Given this list of marker genes Slc16a8, C1qb, Sgce, Sbpl, Grm3, Lipe, Slc31a1, Slc9a2, Hsp90ab1, Slc19a1, Jcad, Rasgrp2, Bbs7, Scimp, Neto2, Adam20, Scn1a, Hk1, Slc6a3, Lin7c, Pten, Snph, P2rx2, Slc6a20a, Grk2, Nsg1, Slc7a8, Dlg4, Trpm6, S100g, Msn, Plb1 (phospholipase B1), Plvap, Gpr37l1, Hspa1a, Atp6v0a4, Unc13a (NCBI Gene Id 73695), Zpld2, Thy1, Comt, Fgd2, Slc7a12, Slc6a8, Ptprt, Lrp6, Sorcs3, Prkcb, Drd3, Sema4f (NCBI Gene Id 20355), Clcn3, Kcnj8, Chrna2, Dpp4, Pkhd1l1, Gabrp, Hsp90aa1, Spry4, Sh3yl1, Slc23a2, Plpp2, Opn4, Slc36a1, Ap2s1, Lrrtm2, Fgr, Ush2a, Slc1a7, Glra1, Cavin3, Lrp4, Slc16a1, Osmr (NCBI Gene Id 18414), Numb, Atp6v1g1, P2ry12, Abcc3, Unc5a, Cdhr5, Gabrr1 (NCBI Gene Id 14408, gamma-aminobutyric acid type A receptor subunit rho 1), Vcam1, Mfsd10, Atp6v0d1, Ptgs2, Ceacam1, Cntn6, Fmr1, Adrb2, Mip, Iqgap1, Abcg5, Pde6g, Smo, Otof, Eps15 (NCBI Gene Id 73669), Src, Il18, Aqp4, Cldnd1, Slco1a1, Adam24, Akr1a1, BC034090, Stim1, Sbp, Slc38a4, Katnbl1, Nkd2, Hmcn1, Tshr, Slco1a4, Pkn2, Prkcg, Znrf2, Cacng5, Sipa1l3, Cldn6, Prkar1a, Cdh2, Magi2, Gabrd, Gpr151, Syap1, Tpm1, Adcy3, Kcnd1, Cldn7, Usp48, Utrn (NCBI Gene Id 22288), Slc26a9, Cask, Racgap1, Slco6d1, Naaladl1, Adam30, Vsig1, P2rx3, Il6ra, Slc8a1, Tamalin, Rapgef6, Ctsk, Adam17, Tacr1, Slc4a2, Abcc4, Kiss1, Gpr179 (G protein-coupled receptor 179), Phb1, Sigmar1, Zmynd10, Dsp, Shc4, Psg27, Bbs9, Cldn19, Tfpi, Dgkb, Nherf1, Slc1a6, Itpr3, Prom2, Oxtr, Krt19, Lcp1, Celsr3, Itga9, Abhd6, Bsn, Rab35, Adcyap1r1, Slco1b2, Itga5, Ms4a1, Htr5a, Slc22a6 (NCBI Gene Id 18399), Slc5a11, Stx3, Fas, Epb41, Gnaq, Pld1, Chrnb4, Vezt, Marcksl1, Slitrk3, Shisa9, Slc2a13, Napepld, Ddr2, Adcy8, Srpx2, Dsg1c, Ajap1, Fsd1 (fibronectin type 3 and SPRY domain-containing protein), Kcnq4, Cnga2, Rigi, Arrb2, Gucy2d, Myo1d, Cldn3, Tcirg1, Slc14a1, Abcb1b, Cripto, Kcnd3, Fermt1, Lrrtm3, Ager, Plppr4, P2ry2, Cav2, Dbn1, Snap29, Ttc8, Cnnm2, Slc20a2, Psg29, Nipsnap1, Kcnq5, Slc9b2, Pde6h, Lrp8, Anxa2 (NCBI Gene Id 12306), Lrfn5, Kcnd2, Neto1, Kctd12b, Rhcg, Cntn5, Gpr161, Mtmr2 (NCBI Gene Id 77116), Rgs9, Musk, Rasgrf1, Megf11, Pcdh8 (protocadherin 8), Eef1a1, Gucy2e, Best1, Dmtn, Slco1a7 (solute carrier organic anion transporter family, member 1a7), Slc12a3, Slc22a26, Slc22a22, Fat1, Slc27a4, Dnm3 (NCBI Gene Id 98663), Cnnm4, Flot2, Cd38, Trpv1, Prkar2a, Slc39a14, Stc1, Pdzd11, Psen2, Mlc1, Prkg2, Slc9a8, Mxra8, Hmcn2, Cdhr1, Drd4, Slc4a5, Rangrf, Abcc1, Slc1a5, Lzts1, Pcdh10, Htr3b, Lrfn4, Hmox1, Slc4a10, Pde4d, Smpd2, Scnn1b, Slc11a2, Adam6a, Trpa1, Cnih3, Pex19, Lhfpl4, Cd55b, Nod1, Cacna2d1, Trpm8, Dcc, Tek, Npy1r, Dram2, Pde6a, Syne1, Ank1, Cldn24 (NCBI Gene Id 434311), Adam21, Folr1, Ctsb, Akap9, Phlpp2, Snap91, Ehd2, Dmd, Kcnj9, Dnm2, Aif1l, Tspear, Plxnd1, Dlgap1, Adam34, Syt7, Chrnb2, Adam9, Gad2, Abcg8, Dcxr, Il1rapl1, Adam29, Septin2, Shisa7, Erc2, Nlgn2, Abca8a, Slc26a7, Cacna1a, Psg25, Olfm1 (NCBI Gene Id 99427), Stx19, Slc28a3, Sapcd2, Slc27a1, Oprl1, Atp1a1, Bmpr1a, Sema4d, Cd36, Myo7a, Glra3, Apc, Slc13a1 (NCBI Gene Id 55961), Rapgef4, Slc4a1, Cdh8, Ninj1, Slitrk5, Anxa13, Ptprh, Ppp1r9b, Tnik, Ptprs, Efna5, Pemt, Chrna5, Abca7, Atp2c2, Clstn2, Lmo7, Crkl (v-crk avian sarcoma virus CT10 oncogene homolog-like), Adam26b, Rala, Ect2, Rapgef3, Cd34, Spire2, Kcne4, Podxl, Rhbg (Rhesus blood group-associated B glycoprotein), Clcnka, Kif18a, Itgb5, Cbln1, Epb41l3, Dnaja3, Tpm3, Slc16a10, Abcb1a, Slc28a2b, Mal, Pth1r, Cavin4, Synj1, Ace (angiotensin I converting enzyme), Strn, Pard6g, Anxa1 (NCBI Gene Id 319730), Igf1r, Ripor2, Aif1 (allograft inflammatory factor 1), Grid2, Aph1a, Plek, Dsg1b, Efnb2, Fzd9, Slc4a4, Slc16a12, Ffar4, Vasp, Kcnj2, Grin1 (NCBI Gene Id 14810), Vdac1, Adam25, Kcne2, Wls, Plxnb1, Slc9a3, Adora3, Psg21, Htr1a, Gp2, Atp7a, Sema4c, Cacna1d, Pld2, Nlgn4l, Slc29a4, Wdr73, Vangl2 (NCBI Gene Id 93840), Pdzk1ip1, Slc7a7, Rab17, Kcnh1, Upk2, Cftr, Car12, Cadm3, Slc7a5, Slc16a6, Grik3, Gabrr2, Ppfia2, Pdxp, Wasf2, Pdgfrb, Fscn3, Inpp5k, Lcp2, Pdzk1, Tmem174, Slc34a3, Slc22a29, Arpc1a, Slc43a3, Pak1, Chrm2, Cit, Slc29a2, Gm4787, Gabra2, Atp4a, Tas2r108 (taste receptor, type 2, member 108), Lrrc4b, Drd2 (dopamine receptor D2), Ctnna2, Slitrk1 (SLIT and NTRK-like family, member 1), Ldlr, Met, Gna12, Anpep, Fosl1, Map4k2, Pick1, Kif20a, Car4, Nme1, Psg19, Ptpra, Kcnk1, Slitrk2, Slc1a2, Ndufs7, Grip2, Ghsr, Slc26a2, Chrna3, Hspb1, Emp2, Pakap, Fzd6, Slc5a2, Ntrk2, Lima1, Ntrk3, Adam1a, Fxyd1, Stxbp1, Prkaa1, Slc29a1 (solute carrier family 29 (nucleoside transporters), member 1), Nrcam, Dok7, Apc2, Slco1c1, Dnajc6, Sorbs2, Slc40a1, Slc16a2 (solute carrier family 16 (monocarboxylic acid transporters), member 2), Pkd1, Gabrq, Atp4b, Mpz, Aurka, Abcb5, Or2a7, Susd4, Nos1ap (nitric oxide synthase 1 (neuronal) adaptor protein), Efnb3, Nradd, Slc17a3, Mpp3, Elfn2 (leucine rich repeat and fibronectin type III, extracellular 2), Adora1, Gpc4, Slc6a9, Slc6a11 (solute carrier family 6 (neurotransmitter transporter, GABA), member 11), Sarm1, Car14, Flrt3, Adam34l, Adam23, Drd5, Naip1, Asic1, Bbip1, Mpdz, Slc16a5, Kctd12, Fxyd2, Iqce, Spef1, Vdr, Sptbn1, Bbs4 (NCBI Gene Id 52291), Eno1, Lrrtm1, Cxadr, Psg17, Pals1, Stxbp2, Grm1, Cys1, Atp2b3, Abcc5, Ndrg4, Gask1a, Cyp4a12b, Stxbp5, Mfsd4b1, Ift46 (intraflagellar transport 46), Pdlim4, Entpd2, Clcn2, Prom1, Cdkl5, Slc5a3, Arhgef2, Dnm1, Grin2b, Ngfr (NCBI Gene Id 18053), Atp6ap2, Lpar2, Gria2, Glra2, Slco1a6 (NCBI Gene Id 73773), Cdc42, Eno2, Kcnn2, Cltc, Cacna2d2, Ano1, Slc2a9, Oprd1, Trappc4, Amn (amnionless), Arrb1, Atp1b3, Atp6v1b2, Cnga1, B4galt1, Nrp2, Amn1, Rgs7bp, Tenm2, Shroom1, Sstr3, Slc5a8, Tirap, Gsg1l, Slc34a1, Alpk2, Cyp4a14, Rhoc, Atp6v0d2, Has2, Cbl, Rab5a, C1qa, Trpv5, Trpc1, Flot1, Stxbp3, Rab8a, Stx1a (NCBI Gene Id 20907), Adora2a, Adgrg2, Pdpn, Prkaca, Hspa8, Cdh9, Slc7a1, Eps8l3, Col13a1, Gabbr1, Dagla, Kcna4, Ncstn, Cyth2, Psd3, Entpd1, Slc30a5, Vamp3, Grin2d, Septin7, Cblif, Kcnc4, Vamp8, Spry2 (NCBI Gene Id 24064), Arhgap45, Map7, Nherf4, Rac1, Ncam1, Atp1b2, Klhdc8b, Htr1b, Atp6v1e1, Slc17a1, Ctbp1, Slc30a1, Slc39a5, Svil, Cd81, Cavin2, Sema4b, Zfyve19 (NCBI Gene Id 72008), Gnat3, Pdia3, Ceacam5, Muc20, P2ry1, Chrnb3, Ace2, Tgfa, Kcnk2 (NCBI Gene Id 98453), Evc2, Gabrg1, Cacng8, Adam26a, Adra2c, Ddr1, Abhd17b, Nod2, Magee1, Myo1c, Igsf11, Slc4a11, Rhoa, Enpp3, Ctsl (cathepsin L), Pard6a, Cav3, Epcam, Tmem114, Atp7b, Gpihbp1, Cdh17, Pllp, Sez6l, Ppp1cc, Slc5a10, Ptprd, Rab25 (NCBI Gene Id 99846), Nlgn1 (neuroligin 1), Pacsin2, Slc4a8, Spred1, Cldn8, Rab18, Sptbn2, Fgf22, Slco6c1, Patj, Slc2a7, Kcnab2, Slco2a1, Pkd1l1, Cyp4a31, Scn8a, Igsf9, Gabra3, Slc51b, Atp2b2, Crhr1, Akap1, Orai1, Thbd, Havcr1, Slc22a28 (solute carrier family 22, member 28), Nbea, Gap43, Gnat1, Ptger3, Slc6a18, Gnb1 (guanine nucleotide binding protein (G protein), beta 1), Kirrel1, Nos3 (NCBI Gene Id 71933), Krt8, Akap6, Slc17a2, Plcg2, Dpep1, Ceacam20, Slc22a5, Snap25, Abcc2, Slc24a4, Cyp4f14, Abcg2, Cd24a, Sytl4, Fscn1, Nrp1, Psd4, Htr3a, Cubn, Lin7b, Gabrb1, Akap7, Ceacam3, Slc7a11, Cdhr2 (NCBI Gene Id 639588), Mapk3, Tmem17, Ano6, Gabrb3, Slc8a3, Abcc10, Fxyd5, Slc13a3, Ryk, Cyp4a10, Slc23a1, Otoa (otoancorin), Slc5a7, Cyth1, Slc2a5, Asic5, Mgam, F2r, Prph, Ms4a4a, Epha7, Crb3, Slco3a1, Scn5a, Ceacam13 (NCBI Gene Id 72256), Cln3, Rab3gap2, Appl2, Mpp4, Epn1, Fxyd4, Chrm4, Shroom2, Abca1, Stx4a, Aqp3, Scarb1, Tmem231, Hax1, Ank3, Cacnb3, Robo2, Tsc2, Napb, Cdh16, Gpr157, Htt, Rims1, Epha2, Ntng1, Heph, Slc22a18, Adam22, Sntg1, Slc5a1, Pcmt1, Dnm1l (dynamin 1-like), Atp2b4, Plcg1, Cav1, Grik2, Septin6, Trpc4, Cnr1, Arf6, Rps3, Chrnd, Pianp, Mttp, Mtss2 (MTSS I-BAR domain containing 2), Adgrl1, Gabre, Scnn1a, Cr1l, Tmem67, Dtnb, Cnga4, Slc12a5, Slc6a5, Cyp4a32, Htr2a, Ncam2, Prrt1, Nherf2, Inppl1, Asic2, Cacng7, Chrna9, Upk1a, Fap, Pde2a, Marveld2, Adam10, Car2, Psen1, Grm7, Slc22a12, Slc34a2, Slc4a9, Kcnc1, Slc22a8, Erbb4, Glrb, Plec, Slc22a21, Neo1, Anxa4, Ctnna1, Nedd9, Aqp5, Farp1, Slc22a30, Gabrg3, Hpca, Cacna1c, Adgrl2, Pkhd1, Diaph1, Arl13b, Mosmo, Adgrl3, Scn11a, Gria1, Jag1, Dsg2, Adam1b, Kcna5, Nptx2, Pip5k1a, Adam4, Grin2c, Myh9, Itsn2, Dab2, Myof, Gnas, Pacsin1 (protein kinase C and casein kinase substrate in neurons 1), Vwc2, Kcnc2 (NCBI Gene Id 544750), Llgl1, Atp1a3, Cfap126, Anp32e, Cyba, Prr7, Wwc1, Calhm1, Prcd, Fzd3, Slc26a11, Slc22a3, Ap2a1, Sorbs1, Eps8l2, Chrna7, Adtrp, Tgfbr1, Slc6a6, Slc6a13, Adam39, Gnb5, Rab11a, Ptpn5, Atg9a, Cspg4, Best2, Prrt2, Prkab2, Cib1, Mtcl1, Shisa6, Cnih2, Slc38a3, Shroom4, Ache, Ezr, Shank3, Clic5, Adcy10, Ptprz1, Tacr3, Tjp1, Fcho2, Pfkm, Myrip, Tfrc, Fbxo2, Ctnnb1 (NCBI Gene Id 12387), Whrn, Kcnj4, Lrp2, Arl13a, Itga6, Shisa8, Scn2a, Micall1, Slc22a13, Fam107a, Cavin1, Pcdh17, Lrfn2, Mapre1, Slc22a19, Cadm4, Aspm, Clstn3, Psd2, Psg26, Kctd8, Nptn, Ptprj, Shank2, Ecrg4, Rtn4, Scrib, Arhgef18, Bcan, Acy3, Lin7a, Prkcz, Grm8 (glutamate receptor, metabotropic 8), Slc6a12, Slc46a1, Chrne, Drd1, Lrrc15, Stk39, Gabrg2, Lrrc4c, Mkln1, Elfn1, Kifap3, Mtdh, Nrg1, Srgap2, Ocel1, Pard3b, Rph3a, Syt11, Slc9a1, C5ar2, Slc28a2, Marcks, Rims2, Igsf9b, Ano2, Nlgn3, Pkd2, Akt2, Tiam1, Bbs1, Picalm, Grin2a, Plcd3 (NCBI Gene Id 72469), Pcdhb16, Tmub1, Kcnj16, Slc26a6, Slc39a3, Atp1b1, Gripap1, Slco4c1, Tbc1d10c, Crb1, Abcg3, Apba1, Slc47a2, Hspa1b, Slc16a3, Pip5k1c, Grin3b, C1qtnf5, Jak2, Chrm3, Rab11fip4, Cacng3, Hvcn1 (NCBI Gene Id 74096), Mylk, Stx1b (syntaxin 1B), Slc22a1, Cd177, Slc10a2, Kcnn4, Ntng2, Psenen, Zdhhc17, Syde2, Grm2, Pik3cb, Rapgef2, Canx, Slc6a20b, Kcnt1, Faim2, Hip1, Kif1b, Itgb1 (NCBI Gene Id 70812), Pde9a, Arc, Arpc2, Ptpro, Gphn, Cacna1h, Antxr1, Car9, Cldn25, Abhd17a, Afdn (NCBI Gene Id 240024), Slc17a4, Plpp1, Enpep, Men1, Grm4, Eppk1, Slc43a1, Slc6a4, Itpr1, Glra4, Ap2m1, Lingo2, Psg20, Npc1l1, Adam11, Chrna10 (cholinergic receptor, nicotinic, alpha polypeptide 10), Ptch1, Gjb6, Slc39a8, Scn10a, Plekha1 (NCBI Gene Id 338490), Lrrtm4, Akap5, Birc5, Psd, Adcy6, Mtmr9, P2rx6 (purinergic receptor P2X, ligand-gated ion channel, 6), Dock8, Oscp1, Slc51a, Ide, Slc47a1, Rims3, Plek2, Clca4a, Psg23, Slc6a19, Stx11, Rnf10, Adgrv1, Eps8, Fasl, Pdgfb, Slc43a2, Chrm5, Slc26a3, Eno1b, Cyp4a30b, Nt5e, Lpo, Nectin3, Slc22a27, Grm5, Chrna4, Ankrd45, Syt6, Epb41l1, 4930544G11Rik, Prickle2, Fxyd6, Ptgis, Iqsec2, Grin3a, Cldn5, Lhfpl5, Lypd11, Slc22a7, Slc12a6, Cacng2, Pard6b (par-6 family cell polarity regulator beta), Slc27a5, Fbxo45, Clstn1, Cdh10, Dtnbp1 (NCBI Gene Id 94245), Slc2a3, Cyp4a12a, Agtr1a, Lrfn1, Spn, Epb41l5, Lrp1, Flrt2, Dstyk, Cntnap2, Bmx, Nde1, Myo6, Cd44, Rhob, Tlr9 (NCBI Gene Id 81897), Itln1, Arf4, Cplx3, Kcnj6, C1qc (complement component 1, q subcomponent, C chain), Gabrr3, Slc15a1, Itga3, Slc14a2, Enpp1, Kctd16, Pappa2, Adgrb3, Slco4a1, Cd9, Abca8b, Rom1, Dll1, Erbb2 (NCBI Gene Id 13866), Gm2a, Bves, Slc2a2, Gpr158, Aqp7, Pitpnm1, Icam2, Ceacam11, Cyp4f18, Atp6v1a, Tmem30a, Twf1, Zc4h2, Syt1, Kcnj3, P2rx1, Scnn1g, Palm, Slc1a1, Sctr, Hcn4, Adgrb1, Crb2, Gabrb2, Napa, Hck, Grik4, Cryab, Itgb4, Kank1, Gpi1, Hpn, Slc7a13, Pard3, Calhm3, Igsf21, Rgs7, Mtmr6, Prkaa2, Syp, Tln1, Slc39a10, Dlg1, Mal2, Casr, Slc3a1, Ddn, Grm6, Nox4, Trpv4, Syne2, Cd300lg, Jup, Adam6b, Ptprq, Gabbr2, Arl6, Aqp1, Ank2, Atp1a2 (NCBI Gene Id 98660), Mchr1, Pde6b, Frmd6, Atf4, Rab11fip3, Ehd3, Gna13 (NCBI Gene Id 14674), Trpc2, Unc13c, Tmem108, Ceacam23, Chrng, Adra2a (adrenergic receptor, alpha 2a), Muc13, St14, Gja1, Kcnma1, Igsf5, Gpr88, Sspn, Frmpd2, Gnao1, Muc17, Dennd1a, Itsn1, Spire1, Lypd4, Clta, Rab21, Syde1, Cyp4a29, Gabra4, Slc26a4, Slc5a12, Chrna1, Cldn4, Ap2b1, Clrn2, Trem2, Bsnd, Nsg2, Pi4k2a, Shank1 (NCBI Gene Id 545962), Atp2b1, Kcna3, Itgb2l, Exoc3, Irs1, Upk1b, Kcnc3, Dlg3, Add2, Sh3bgrl3, Itpk1, Slc7a9, Baiap2, Notch1, Kcnj11, Amotl1, Txndc15, Slc9a4 (NCBI Gene Id 98735), Slc26a1, Syt3, Atp8b1, Ssh1, Nectin1, Cdh15, Kcnq1, Ptk2, Ttyh1, Clca2, Rp2, Lamp5, Bmpr2, Slco1a8, Lct, Gria3, Nrxn3, Plk4, Abcb4, Apbb1, Efcab7 (NCBI Gene Id 381610), Pkn1, Insr, Inpp5j, Hcn2, Aqp8, Upk3a, Bsg, Clmp, Gabra1, Cnksr2, Myo1a, Trf, Htr7, Rab14, Syndig1, Stk26, Cd46, Map2, Evc, Gria4 (glutamate receptor, ionotropic, AMPA4 (alpha 4)), Kl, Slc12a1, Kncn, Il10ra, Cpe, Hdac6, Slc13a5, Slc6a14, Csmd2, Clasp2, Cldn1, Septin3, Myh10, Ptprf, Slc28a1, Dlc1, Lypd10, Mpp2, Dgki, Plpp3 (NCBI Gene Id 68448), Chrna6, Ldlrap1, Otog, Gper1, Grik1, Plet1, Gpr156, Robo1, Actn2, Hpgd, Rapsn, Cdh13, Tgfbr2, Slc39a4, Itgb2, Cacng4, Cntn2, Macf1, Gabra5, Slc38a1, Wdpcp, Ctnnd1, Nrxn2, Dag1, Slc22a4, Ptpn11, Rdh11, Slc6a1, Sorcs2, Fgd5 (FYVE, RhoGEF and PH domain containing 5), Cadm1, Slc44a4, Cntnap4, Pnoc, Asah2, Slc17a5, Slco2b1, Igfbp2, Slc39a6, Clcnkb, Mapt, Hyal2, Gm1123, Ahcyl1, Slco5a1, Synj2, Cspg5, Slc15a2, Nrgn, Efnb1, Stambp, Slc8a2, Snta1, Cltrn, Lrrk2, Kcnj10, Kcna2, Rab27b, Kcna1, Dbnl, L1cam, Them4, Diaph3, Mapk8ip3, Atp12a, Ceacam2, Iqsec3, Spata13, Car11, Pip, Tex101, Muc4, Slc9c1, Olfm2, Cep55, Pstpip1, Lpar1, Ocln, Slc3a2, Rho, Myo10, Plekhg6, Grik5, Hcn1 (hyperpolarization activated cyclic nucleotide gated potassium channel 1), Reg1, Gabra6, Prtn3, Grid1, Nf2, Cfl1, Lrrc4 (NCBI Gene Id 192198), Mapk1, Cdc37, Cntfr, Kcne1, Cd55, Neu3, Oprm1, Lepr, Slc41a1, Adra1a, Slc5a6, Mreg, Shroom3, Slc16a7, Adcy1, Cdh1, Cyp4f15, Rab27a, Nckap1, Atad1, Chrnb1, Tmem240, Piezo1, Pla2g4f, Mcoln3, Aqp9, C5ar1, Amotl2, Coro1c, Gpm6a, Atp6v1b1, Abcc6, Dlg2, Cd8a, Kif17, Cacna1e, Tesc, Tjp3, Slc13a2, Nos1, Itgav, Cntn1, Erbin, Pkd2l1, P2ry6, Oprk1, Slc26a5, Cacna2d3, Sele, Slc2a1, Abhd17c, Tmem235, Scn3a, C2cd5, Itgb3, Slc4a7, Egfr, Cnksr3, Fermt2 (NCBI Gene Id 218952), Chrm1, Umod, Slc9a5, Ksr1, Rdx, Unc13b, Abcb11, Gpr143, Nrxn1, Cadps2, Ephb2, Dctn3, Cltb, Ajm1, Mastl, Mfrp, Il31ra, Lrfn3, Ehd1 (NCBI Gene Id 13660), Grip1, Tenm3, Bbs2, P2ry4, Eps8l1, Anxa6, Septin5, Slc6a2, Cybrd1, Stx2, Epha4, Slc1a3, Aqp2, Itga8, Hip1r, F2rl2, Muc1, Erbb3, Rap2a, Bbs5, Slc6a7, Psg28, Hjv, Tacstd2, Lrrc7, Skap1, Gabarapl1, Plekho1, Kcnb1, Slc12a2, C2cd2l, Rims4, Slc22a2, Prkci, Grid2ip, Acp4, Fn1, Dsg1a, Adra1b, Itgam, Selplg, Sh2d3c, Bst2, Slco1a5, Slc10a1, here is a description of the gene set: A membrane that is a (regional) part of the plasma membrane. studied in species Mus musculus Mouse Gene Set: GOCC_PLASMA_MEMBRANE_REGION